Given this list of marker genes ILF2, ATP5MC1, SSBP1, ACLY, TCEA1, HNRNPD, VDAC2 (voltage dependent anion channel 2), SLC25A5, HUWE1, CAPZA1, VARS1 (NCBI Gene Id 7407), NDUFV1, SSRP1, PPIE, ZPR1, CLPP, MAP2K2, RNPEP, GPN1, MLEC, DCTD, YARS1, PKMYT1, MRPL9, SOD1, IMPDH1, PDIA6, NDUFS5, SSB, UQCRH (ubiquinol-cytochrome c reductase hinge protein), YWHAQ, SRP72, NAE1, XRCC6, SAFB, DNMT1, CYCS, LDHB, PPM1G (protein phosphatase, Mg2+/Mn2+ dependent 1G), HCCS, VDAC3, TIMM17A, DAP3, RTCB, MRPS18B, MYDGF (myeloid derived growth factor), XPO1, ARIH2, HSP90B1, THOP1, AK2, HNRNPC (heterogeneous nuclear ribonucleoprotein C), IARS1, MCM2, EIF4A1, CYC1, CCT2, EIF3K, TOMM20, WDR18, EIF1AX, VDAC1, GANAB, SUMO2, DEK, PCMT1, FH (NCBI Gene Id 83748), AKR7A2, CDK2, G3BP2, ALG3, OXA1L, RPIA, NONO, POLR2C, TXNL4A, ATF4, RO60, RFC4, DOCK3, PSMB2 (NCBI Gene Id 5690), PGK1, CSK, NDUFS2 (NCBI Gene Id 4720), AFG3L2, LYPLA1, NSA2, LSM2, HSPE1, PABPC4, EIF3H, TUBA3C, EIF3I, MDH1, HDAC2, RPN1, KHDRBS1, DUT, BAG6, SLC25A3, CAPRIN1, PSMD2 (NCBI Gene Id 5708), RUVBL2, CEBPZ, ZNF131, SET, YBX1, PRKDC, UQCRFS1, NDUFA7, PRPF31, COPS2, CS, EIF4EBP2, LDHA, BAZ1B (bromodomain adjacent to zinc finger domain 1B), PPIB, DNAJC8, UBE2I, NPM3, FUS (FUS RNA binding protein), CAD, LSM4, PPP2R1A, ATP5MC3, KXD1, U2AF1, GNG5, GCN1, GPAA1, CSNK2B, UBE2L3, DEAF1, MTREX, TCP1, SNRPA, TXLNA, CIAO1, DKC1 (NCBI Gene Id 1736), RSL1D1, EIF3D, PTDSS1 (NCBI Gene Id 9791), STARD7, ILF3, UBA2, RHEB, PRPF8, TCOF1, CCT7, PRKAG1, PTGES3, DRG1, PARK7 (NCBI Gene Id 113880), NUP188, PABPN1, DDX39B, ESD, IMMT, CHAF1A, SNRNP200, AATF, SERBP1, SERP1, RAD23A, SLC3A2 (NCBI Gene Id 6520), NUDT1, ACP1, DDX19B, LRPPRC, SRSF9, POLR2A, SF3A2, FAM168B, HADHA, ATXN10, COQ9, NUDC, TBL3, SAMM50, PDHB, XRCC5, CELA2A, FIBP, IFRD1, POLE3, CCT4, GPI, MRPS27, TARS1, GNB2, H2AZ1, IMPDH2, PIN1, PSMA1, HNRNPR, CDV3, HADH, NAP1L4, SNRPE, PPP1CC, TOMM70, SREBF2 (NCBI Gene Id 6721), DDX49, EPRS1, RPL14, RPA2, RAD54L, ATP5F1A, DDOST, PHB2, ANAPC5, EIF4H, EIF3M, POM121, NAP1L1, ZC3H15, GNB1, SDHB, POLR2I, BUB3, SLC4A2, FBL, SRRM1, CLNS1A, TUFM, ATP5F1D, IDH3B, DEXI, DGUOK, EBP, XPO7, GTF2A2, CBX3, PSMB7, RNPS1, AP3S1, CTDNEP1 (CTD nuclear envelope phosphatase 1), NCL, EIF2S2, HNRNPAB, LSM7, BRD8, ATP5PO, HNRNPA2B1, PRPS2, SRM, here is a description of the gene set: Human Gene Set: MORF_EIF3S2 studied in species Homo sapiens Neighborhood of EIF3S2 eukaryotic translation initiation factor 3, subunit 2 beta, 36kDa in the MORF expression compendium Neighborhood of EIF3S2